Given this list of marker genes Hmgb3, Asf1b, Mrpl12, Cetn3, Eif3g, Anp32b, Rpl10, Tmsb4x, 0610010K14Rik, Fh1, Ndufs8, Cenpe, Aurkb, Timm17a, Neil3, Phgdh, Nol7, Psmc4, Ptov1, Naxe, Pih1d1, Bex3 (brain expressed X-linked 3), Cuta (cutA divalent cation tolerance homolog), Cfl1, Cltb, Wdr89, Rpl41, Esd, Hpf1, Gnb1, Rex1bd, Ubb-ps, Snrpd3, U2af1, Ahcy (NCBI Gene Id 98842), Bola2, Cotl1, Tle5, Plac8, Srsf3, Hmgn5, Bcas2, 2610318N02Rik, Rfc4, Erp29, Atp5pf, Mrpl54, Gpx1, Exosc8, Nt5c3b, Naa38, Eif1, Atp5pb, Esco2, Nop53, Tex261, Ndufb8 (NCBI Gene Id 67264), Dhfr, Rps13, Tuba1b, Mrpl23, Ppp1r35, Mrpl51, Ndufb5, Ranbp1, Mrps14, Denr, Pgp, Siva1, Mrpl42, Smc4, H3f3b, Hmmr, Ccdc124, Impdh2, Nasp, Ptprcap, Rps20, Ube2k, Rpl32, Prelid3b, Snrpd1, Pdcd5, Mospd3, Chchd1, Gins2, Rpl27, Kif23, Phb1, Tk1, Racgap1, Psmc1, Ssna1 (SS nuclear autoantigen 1), Snrpa, Mrto4, Pclaf, Naa10, Ndufb6, Psmb2, Mrpl30, Reep5, Eif3k, Pmf1, Csnk2b, Cmc2, Rpl29, Stmn1, Prc1, Aurka, Mrps12, Fam162a, Mad2l1, Ndufb2, 1700097N02Rik, Calm2, Tmsb10, Smc1a, Mtch2, Eif3e, Gadd45gip1, Kif22, Mrpl2, Cenpx, Tmed10, Cenpk, Ebna1bp2, Rpl5, Grpel1, Psmd7, Micos10, Cdkn3, Ran, Tipin, Eif3f (eukaryotic translation initiation factor 3, subunit F), Nelfe, Macroh2a1, Nme1 (NME/NM23 nucleoside diphosphate kinase 1), Cd3g, H2aj, Park7, Mrps24 (NCBI Gene Id 67297), Eif3i, Smco4, Ppib, H2ax, 1500009L16Rik, Lage3, Calm3, Anapc11, Cyba (NCBI Gene Id 13057), Cfdp1, Slirp, Ddt, H2az2, Psma2, Rps27a, Ndufb7, Calm1, Rplp1, Psmc3, Rps5, Mrps11, Myl6, Ccna2, Commd1, Gmfg, Bsg, Serbp1, Nedd8, Swi5, Cdca8, Etfb, Cox6c, Mrpl14, Polr2l, Rpl23, Ube2c, Tmem97, Ddx39b, Fxn, Btf3, Nusap1, Ybx1, Dcps, Psma4, Uba52, Abracl, Uqcrh (ubiquinol-cytochrome c reductase hinge protein), Slc25a3, Crip1, Ska1, Acot7, Clta, Glrx3, Gnl3, Tagln2, Rplp0, Polr2c, Rps26, Tceal9, Tpx2, Fdps, Rpl7, Rpl4, Uqcrc2, Rps6, Ndufc2, Rfc3, Cdca2, Dut, Uchl5, Rpl7a, Tmem14c, Thoc7, Rps17, Sf3b5, Cdk4 (cyclin dependent kinase 4), Mrpl36, Psme2, Incenp, Nop58, Fabp5, Eef1d, Rpl19, Timeless, Slbp, Tomm6, Atp5f1d, Ostc, Clic1, Pa2g4, Erh, Cirbp, Rps18, Tubb2a, Ndufa7, Psmb8, Smc2, Ndufb9, Gmnn, Ube2s, Hdgf, C1qbp, Rps14, Psmb6, Pomp, Lsm5, Utp11, Ftl1, Pgk1, Cdc45, Rpl23a (ribosomal protein L23A), Tomm20, Rpl22, Hmgb2, Pin1, Snrnp27, Psma5, Vcf1, Cenpf, Eif2s2, Gar1, Ddx39a (DEAD box helicase 39a), Rps3a1, Jund, Psma3, Rbm25, Rpl8, Rpa2 (NCBI Gene Id 99984), B2m, Dnajc8, H2ac11, Ap2s1 (adaptor-related protein complex 2, sigma 1 subunit), H2ac8, Rbmxl1, H2-D1, Ube2t, Rpl17, Eef1b2, Lgals9, Ndufa10, Rps3, Rps23, Cks1b, Dbi, Sdhb, Ppia (peptidylprolyl isomerase A), Pfn1, Fbl, Cdkn2c, Limd2 (NCBI Gene Id 67803), H2-Ab1, Bola3, Pabpn1, Nt5dc2, Pfdn4, Trir, Hmgb1, Ak2, Myl12a, Gtf2f2, Smc3, Tomm40, Spc25, Rps9, Rpl21, Fundc2, Rheb, Txn1, Cdk1, H2-K1, Dpy30, Taf10 (NCBI Gene Id 24075), Exosc7, Cenps, Atp5if1, Hsp90aa1, Sdf2l1, Ubxn1, Snrpg, Rpl22l1, Rpl11, Dnajc9, Hsp90ab1, Psma6, Emc10, Rpl28, Stub1, Ndufa12, Eif3m, Nsa2, Cox8a, Psmg2, Ptp4a3, Apex1, Pafah1b3, Rbis, Uchl3, Comt, Lyar, Prim1, Tmem242, Ptma, Micos13, Lamtor1, Dynlrb1, Cdca3, Rpl31, Manf, Srm, Adh5, Rps16, Rpl18, Exosc5, Spc24, Psma1, Pcbd2, Eif1ax, Cdc123, Mrps26, Metrn, Clspn, Zcchc17, Anxa2, Rpl3, Rbm8a, Nudc, Rps10, Psmc2, Ppp1ca, Emd, Tecr, Smdt1, Ppil1, Rpl15, Rhno1, Sf3b2, Birc5, Mxd3, Mrpl27, Ddah2, Psmb1 (NCBI Gene Id 98079), Rpl27a, Prelid1, Fth1, Pfdn6, Snrnp25, Knl1, Syce2, Sf3b4, Ckap2l, Mrps15, Raly, Drap1, Ndufb10, Rpl36, Dgcr6, Rps12, Rps8, Rpl14, Ndufa9, Tmed9, Rpl13a, Jtb, Stoml2, Cks2, Ppie, Phb2, Poc1a, Rpl35, Plp2, Psmd4, Snrpb, Timm17b, Arpc5l, Hnrnpd, Nap1l1, Tubb5, Vrk1, Nxt1, Eef1g, Magoh, Banf1, Atp5pd, Fmc1, Snrpa1 (NCBI Gene Id 68981), Rfc2, Psmc3ip, Phf5a, Phpt1, Dek, Pmm1, Eif5a, Tbcb, Gzma, Fbxo5, Sumo1, Rps2, Cenpa, Snrnp70 (NCBI Gene Id 97422), Rpl36a, Rps11, Cenph, Knstrn, Sfxn1 (sideroflexin 1), Oxct1, Tmem160, Snrpc, Psmb9, Atp5mc2, Sin3b, Rack1, Mrpl18, Dnajc2, Nhp2, Psme1, Rrm2, Slc25a5, Txn2, Emp3 (epithelial membrane protein 3), Akr1a1, Mrpl52, Mns1 (meiosis-specific nuclear structural protein 1), Ssbp4, Alyref, Cycs, Dkc1, Cox5a (NCBI Gene Id 12858), Mdh1, Galk1, Llph, Cst3, Mrpl20, Lsm3, Ppih, Rpl6, Ndufb11, Cenpw (NCBI Gene Id 674508), Prdx1, Atp5mg, Rnaseh2c, Ccnb2, Snu13, Tubg1, Snrnp40, H2ac23 (NCBI Gene Id 665433), Nudcd2, Fkbp3, Hnrnpab, Sdhc, Erdr1, Tubb2b, Npm3, Psmb5, Tpt1, Rexo2, Gtf3a, Aarsd1, Ppig, Antkmt, Gtf2a2, Mrps16, Rps4x, Orc6, Pfdn1, Rpa3, Shmt2, Ccdc34, Tubb4b, Elof1, Rnaset2b (ribonuclease T2B), Ly6e, Pdlim1, Tsn, Elob, Vdac2, Gapdh, Etfa, Fkbp2, Tpm3, Cops5, Mif, Mrpl13, Bcl7c, Hprt1, Top2a, Pgls, Chchd3, Sumo3, Nme2, Fau, Lat, Rad51ap1, Atp5f1c (NCBI Gene Id 80670), Sap30, Rpl24, Ciao2a, Myl10, Capzb, Arpc3 (actin related protein 2/3 complex, subunit 3), Aimp1, Nrm, Eef1e1, Cyc1, Aurkaip1 (NCBI Gene Id 66077), Nubp1, Nudt1, Ndufa8, Smc6, Tkt, Ndufs7, H2-T10, Rps24, Nsmce1, Srsf7, Rgs10, Rnaseh2b (ribonuclease H2, subunit B), Lockd, Dnajc19, Nucks1, Lig1, Ndufs6, Naca, Uqcc2, Yif1b, Cacybp, Bzw2, Ndufc1, Chmp2a, Rps7, Pebp1, Ldha, Exosc6, Pold2, Plk1, Arpp19, Adrm1, Set, 1110004F10Rik, Mrpl58, Tuba4a, Ptms, Ndufv2, Gins1, Rpsa, Bag1, Utp3, Rplp2, Arhgdia, Rpl9, Hmgn2, Psmb4, Pdap1, Psmd8, Eny2, Dtymk, Cox4i1, Tcf19, Hmgn1, Trp53, Prdx4 (NCBI Gene Id 53381), Rpl18a, Tmem256, Lsm2, Ptcra, Pbk, Polr2g, Gpx4, Sod2, H3f3a, Polr2f, Ube2l3, Atp5po, Chchd2, Rpl13, Mdh2, Oaz1, Taf9, Rps15a, Gtf2h5, Bub3, Pcna, Rps15 (NCBI Gene Id 20054), Hnrnpdl, Tomm5, Rps19, Nsmce4a, Rbm3, Lsm4, Sod1, Atp5mc1, Pla2g12a (phospholipase A2, group XIIA), Hint1, Arpc1b, Sfr1, Dctpp1, Mrps18c, Eef1a1 (NCBI Gene Id 13627), Atp5mc3, Acp1, Cdc20, Snhg3, Wdr83os (WD repeat domain 83 opposite strand), Sarnp, Anp32e, Arl6ip4, Selenoh, Mrps33, Mrpl28, Npm1, Ncl, Rpl10a, Tpi1, Hspe1, Cenpm, Cisd1, Dad1 (NCBI Gene Id 13135), Txnl1 (thioredoxin-like 1), Snrpd2 (NCBI Gene Id 69107), Tyms, Pabpc1, Psma7, Tuba1c, Dynll2, Mpc2, Polr2e, Ppa1, Rwdd1, Rp9, Rpl12, H2az1, Ubb, here is a description of the gene set: Mouse Gene Set: TABULA_MURIS_SENIS_THYMUS_THYMOCYTE_AGEING from publication Tabula Muris Consortium (PMID 32669714) species: Mus musculus